The following is a description of a gene set: studied in species Homo sapiens A transmembrane protein complex located in the endoplasmic reticulum (ER) involved in the insertion of newly synthesized proteins in the membrane of the ER. In S. cerevisiae, it has six members: EMC1, EMC2, AIM27, EMC4, KRE27, and EMC6. Human Gene Set: GOCC_EMC_COMPLEX, and this is the list of marker genes: EMC10, EMC8, EMC4, EMC6, EMC7, EMC1, EMC9, MMGT1, EMC3, EMC2